Given this list of marker genes B3GALT2, FA2H, B3GALT1, UGT8 (UDP glycosyltransferase 8), PRKAA1, B4GALT3, UGCG, GAL3ST1, here is a description of the gene set: studied in species Homo sapiens Human Gene Set: GOBP_GLYCOSYLCERAMIDE_BIOSYNTHETIC_PROCESS The chemical reactions and pathways resulting in the formation of glycosylceramides, any compound formed by the replacement of the glycosidic hydroxyl group of a cyclic form of a monosaccharide (or derivative) by a ceramide group.